Given this list of marker genes PHIP, RPL10, ZMIZ1, FIG4, HIVEP2, AHDC1, MYMK, TRIO, KCNE5, KDM5C, GJA1, WNK1, PIGV, NR2F1, PCGF2, EIF2S3, HUWE1, AIP, RETREG1, RNU4-2, SMARCAD1, SMC1A, SMARCA2, MAPK1, SLC25A12, H4C5, UNC80, DYRK1A, SPEN, RUNX2, ZFX, COL12A1, LAS1L, RAB11B, VAC14, MAGEL2, KATNB1, PRR12 (NCBI Gene Id 57479), TBCK, MAP1B, KDSR, TCF20, WASF1, TNNT3, HEATR3, NAA80, KDM1A, MAF, SUPT16H, CDKL5, KIFBP, SIM1, PHF21A, IRX5, SLC4A10, PIGA (phosphatidylinositol glycan anchor biosynthesis class A), EXOC6B, KMT2C, ADNP, TP53RK, INPPL1, PIGN, ODC1, RNF13, GJB3, RUSC2, CHST14, ADAMTSL1, CRELD1, SVBP, ATRX, CDC42BPB, DPH5, PHF6, CPT2 (NCBI Gene Id 1376), ARX, EXOSC5, SLC25A46, OTUD6B, LMNB2, CTCF, TRAPPC9, ASXL1, IARS2, GATA2, CHD4, CRLF1, MAPRE2, GNB2, GJB4, H3-3A (H3.3 histone A), CDC42, FBXO11, GNB1, COPB1 (COPI coat complex subunit beta 1), TELO2, EHMT1, PAX1 (paired box 1), SETD1B, CNOT3, SCARF2, PRKAR1B, AMMECR1, CCNK, MTHFS, DSE, MYOD1, BCORL1, SLC32A1, KMT2E, SPOP, GNAI1 (G protein subunit alpha i1), ACBD6, SLC12A6, ZMYM2, DOCK3, ZNHIT3, BRF1 (BRF1 RNA polymerase III transcription initiation factor subunit), HECTD4, PRIM1, CCDC88A, USP9X, HDAC8 (NCBI Gene Id 7492), KMT2A, SNIP1, GATA4, VPS13B, KIF7, EBF3, PUM1, DLX5, SLC39A13, CLP1, SCN9A, GPR101, CNOT1, RPS6KA3, TCF4, DDX6, PIGB, DPYSL5, KIF1A, ECE1, DHX30, TFE3, H3-3B, ACSL4, TRPM3, here is a description of the gene set: Human Gene Set: HP_TAPERED_FINGER species: Homo sapiens Tapered finger The gradual reduction in girth of the finger from proximal to distal.